The following is a description of a gene set: studied in species Homo sapiens This HIV-1 event was inferred from the corresponding human RNA Poll II transcription event. The details relevant to HIV-1 are described below. Formation of the early elongation complex involves hypophosphorylation of RNA Pol II CTD by FCP1P protein, association of the DSIF complex with RNA Pol II, and formation of DSIF:NELF:HIV-1 early elongation complex as described below. part of: HIV Transcription Elongation Reactome Pathway: Formation of the HIV-1 Early Elongation Complex, and this is the list of marker genes: NELFE, NELFB, POLR2G, NCBP1, POLR2C, GTF2H5, POLR2A, POLR2H, POLR2E, CTDP1, POLR2F, SUPT4H1, POLR2J, ERCC3, GTF2H4, GTF2F1, POLR2D, POLR2L, GTF2H3, GTF2H1, POLR2B, NELFCD, NELFA, GTF2F2, SUPT5H, NCBP2, ERCC2, CDK7, CCNH, GTF2H2, POLR2I, MNAT1, POLR2K